Given this list of marker genes Nr4a1, Hnf4a, Esr2, Nr2f2, Pgr, Nr5a2, Ppard, Esr1, Ppara, Rxra, Nr4a2, Rarg (retinoic acid receptor, gamma), Thrb, Nr1i2, Nr1d2, Esrra, Vdr, Nr2f1, Ror1, Rara, Rxrb, Nr2e1, Nr3c1, Nr5a1, Rora, Nr1h3, Nr2f6, Pparg, Esrrb, Nr0b1, Thra, Nr1i3, Ar, Nr2c2, Rxrg, Nr1h2, Rarb, Rorc, here is a description of the gene set: Nuclear Receptors Mouse Gene Set: WP_NUCLEAR_RECEPTORS species: Mus musculus